Given this list of marker genes Gata2, Dmrt3, Nkx2-2 (NCBI Gene Id 228734), Shh, Dbx1, Evx1, Gli2, Lmo4, Gli3, Ascl1, Pax6, Sufu, Foxn4, Lhx3, Dll4, Sox1 (SRY (sex determining region Y)-box 1), here is a description of the gene set: Mouse Gene Set: GOBP_VENTRAL_SPINAL_CORD_INTERNEURON_DIFFERENTIATION studied in species Mus musculus The process in which neuroepithelial cells in the neural tube acquire specialized structural and/or functional features of ventral spinal cord interneurons. Ventral spinal cord interneurons are cells located in the ventral portion of the spinal cord that transmit signals between sensory and motor neurons and are required for reflexive responses. Differentiation includes the processes involved in commitment of a cell to a specific fate.